The following is a description of a gene set: Vertebral clefting species: Homo sapiens Human Gene Set: HP_VERTEBRAL_CLEFTING Schisis (cleft or cleavage) of vertebral bodies., and this is the list of marker genes: SOX2, IPO8, LAMA5, SOX5, ALPL, MESP2, CHST3, TBXT (NCBI Gene Id 6862), TRPV4, TBX6, CHRNG, TRIP11, STAG2, NKX3-2, ALDH1A2, HAAO, SLC26A2, RIPPLY2 (NCBI Gene Id 134701), IARS2, WBP11, FLNB, ALG12, HSPA9, SC5D, RAD21, FOXF1, ARSL, OTUD5, KMT2D, HSPG2, COL2A1, CSGALNACT1, KDM6A, PEX7, GNPAT, MBTPS2, SLC10A7, COG1, SIX6, COL11A2, LONP1